Given this list of marker genes Nup62cl, Nup62, Nup35, Nutf2, Nxt1, Nutf2-ps1, Nup54, Nxt2, here is a description of the gene set: species: Mus musculus Mouse Gene Set: GOCC_NUCLEAR_PORE_CENTRAL_TRANSPORT_CHANNEL The central substructure of the nuclear pore complex (NPC), through which nucleocytoplasmic transport of RNAs, proteins and small molecules occurs. The central transport channel is filled with FG-nucleoporins, which form a selective barrier and provide a series of binding sites for transporter proteins. Characterized S. cerevisiae FG-nucleoporins include Nup159p, Nup145Np, Nup116p, Nup100p, Nsp1p, Nup57p, Nup49p, Nup42p, Nup53p, Nup59p/Asm4p, Nup60p and Nup1. Characterized vertebrate FG-nucleoporins include Nup214, Nup98, Nup62, Nup54, Nup58/45, NLP1, and Nup153.